Given this list of marker genes MIR127, GBA1, GALC, SCARB2, GLA, MIR195, MIR16-1, LCT, GBA3, GBA2, PRKCD, here is a description of the gene set: The chemical reactions and pathways resulting in the breakdown of glycosylceramides, any compound formed by the replacement of the glycosidic hydroxyl group of a cyclic form of a monosaccharide (or derivative) by a ceramide group. studied in species Homo sapiens Human Gene Set: GOBP_GLYCOSYLCERAMIDE_CATABOLIC_PROCESS